Given this list of marker genes LRIT2, GABARAPL2, SPATS1, PLEKHG5, KRTAP4-7, VIPR2, PDE6B, PHEX, KCNC2, CRIPT, FEZ1, NSUN7, VASH1, TMEM158, C11orf16, CRH, PMVK, NPHP1, FAM90A13, ASB1, BNC2, KRT10, TENT5B, GREB1, LAD1, BPGM (bisphosphoglycerate mutase), RHBG, COL3A1, ZNF248, ASPM, SFRP4, SLC27A3, MRPL49, GPR12, CRHBP, EHHADH, GIGYF2, HMX3, GUCY2C, DRC12, MYF6, AEBP1, ALMS1, MYOD1, CD1D, SLC25A3 (NCBI Gene Id 5250), UQCRFS1, GPR137, TMEM184A, PCDH17, SUPT4H1, HOXC10, LECT2, APCDD1, ANKRD22, PPP1R14C, CNBP, TCTN3, C14orf39, TNFSF9, NYX, CYP4A11, NGFR, TMEM225, ARG2, PRSS53, JAKMIP3, FOXI1, ADAMTSL5, LEF1, PDGFRL, ALPG, NRN1L (NCBI Gene Id 123904), C3orf22, STARD13, FREM2, AGRP, WDR73, EMC8, ILKAP, CA13, SARS2, SLC35F4, MUC16, CYP11B1, DCST1, KCNJ13, ZNF560, LDAF1, SIRT5 (sirtuin 5), CADPS2, KCNN3, LAPTM4A, HBP1, IFNB1, VSTM2B, CFHR2, ATRAID, SYN3 (NCBI Gene Id 8224), CYGB, NPFFR2, KCNE3, SLC2A12, TRIR, VAT1L, CD209, CLTB, MEA1, BCL9, NOB1, KBTBD3, ST6GALNAC3, MYO3A, GSTM2, SLC22A16, BRS3, HSD17B11, CDH9, GPRIN2, LRRIQ3, PSD, GARIN3, CDH11, AMY2A, SLC15A1, OXGR1, PRICKLE2, PSMD1, SCAI, CXCL6, DNAJC11, SYT13, MAPRE3, ARFGEF3, ACTL7A, MAMDC2, CALN1, PIGB, OR2T33, TMCO2, DPYS, SELENOS, UBE2U, MRLN, MRPL46, IGDCC3, ST3GAL4, SOX2, PKDREJ, PRR32, POU2AF1, VWA5B2, AKR1D1, GABRA5, MIXL1, SYCP2L (NCBI Gene Id 387105), FGF4, SYCP3, DLX1, SSR4, NKAIN2, EVA1C, RPS9, AMZ2, MRPS24, IYD, CWH43, KLRC2, PLXNA1, EAF2, TFAP2D, SYDE2, SMARCE1, TNFRSF25, TMEM17, TRAF4, MMS19, AFAP1L2, KCNJ16, RAB36, CAVIN2, PKHD1, MS4A1 (NCBI Gene Id 931), SPAG1, CD207 (CD207 molecule), MYH3, SLC6A19 (NCBI Gene Id 8062), LRRTM1, PLCZ1, CBY3, DEFB119 (NCBI Gene Id 245933), FGF7, MNS1, NUDT13, MFSD13A, PRSS41, MYO1E, PM20D1, CRYZL1, here is a description of the gene set: species: Homo sapiens Human Gene Set: GSE46606_UNSTIM_VS_CD40L_IL2_IL5_3DAY_STIMULATED_IRF4HIGH_SORTED_BCELL_DN Genes down-regulated in at day 0 B cell IRF4-KO versus CD40L and IL-2 IL-4 IL-5 stimulated at day 3 B cell IRF4high. from publication Ochiai K, Maienschein-Cline M, Simonetti G, Chen J, Rosenthal R, Brink R, Chong AS, Klein U, Dinner AR, Singh H, Sciammas R (PMID 23684984) Temporal analysis of B cell activation in vitro using CD40L and IL-2/4/5 cytokines in wild type Irf4+/+ B cells or in mutant Irf4-/- B cells harboring a tet-inducible allele of Irf4. IRF4 expression was restored, or not, in the Irf4-/- background by culturing in the presence of low or high concentrations of doxycycline. The results provide insight in the role of IRF4 expression levels in coordinating different programs of B cell differentiation.